The following is a description of a gene set: species: Mus musculus Mouse Gene Set: GOBP_GTP_BIOSYNTHETIC_PROCESS The chemical reactions and pathways resulting in the formation of GTP, guanosine triphosphate., and this is the list of marker genes: Nme6, Nme1, Nme2, Pnp, Nme5, Nme4, Impdh2, Nme3, Impdh1, Nme7, Impdh2-ps